Given this list of marker genes Bmp6, Mepe, Nfe2, Bglap2, Actn3, Txlng, Calcr, Intu, Enpp1, Trpm4, Ccn1, Fzd9, Rflna, Gata1, Prl, Gpm6b, Lrp6, Fgfr3, Dlk1, Oxt, Ptger4, Zmpste24 (zinc metallopeptidase, STE24), Smad3, Csf1, Calca, Tgfb1, Bcor, Bmpr2, Fbn2, Smad6, Fgf23, Mkx, Ltf, Smurf1, Gdf10, Atraid, Ccdc134, Ccr1 (C-C motif chemokine receptor 1), Tob2, Smad2, Kremen1, Suv39h1, Rxrb, Nell1, Bglap3, Ahsg, Sfrp1, Sgms2, Rsad2, Creb3l1 (cAMP responsive element binding protein 3-like 1), Mapk1, Gja1, P2ry2, Srgn, Tent5a, Matn1, Cnmd, Bmp2 (NCBI Gene Id 98992), Asxl2, Adrb2, Osr1, Chsy1, Osr2, Grem1, Acvr2a, Fam20c, Sox9, Setd2, Runx2, Egr2, Ccr1l1, Slc8a1, Atp2b1, Comp, Ptk2b, Tacr1, Thrb, Wnt5a, Phospho1, Nipbl, Wnt4, Pth, Ano6, Mdk, Pkdcc (protein kinase domain containing, cytoplasmic), Nbr1, Bmpr1a, Dhrs3, Bglap, Isg15, Ostn, Mia3, Mapk3, Tmem53, Pbx1, Vdr, Ptpn11, Tac1, Notch1, Tmem119, Adgrv1, Bcl2, Ccn3, Ddr2, Adcy10, Dkk1 (NCBI Gene Id 13380), Alox5, Lrp4, Bmp7, Twist1, Mgp, Acvr1 (NCBI Gene Id 11478), Tfap2a, Ptn, Mapk14, Ltbp3, Notum, Sox11, Zbtb16, Hif1a, Six2, Rflnb, Tph1, P2rx7, Ecm1, Acvr2b, Kremen2, Slc20a2, Cd276, Smad7, Bmp4, Kl, Ank (NCBI Gene Id 52488), Rbpj, Mef2c, Sost, Csf1r, Wnt10b, Acvr1b, Bmpr1b, Cyp27b1, Esrra (estrogen related receptor, alpha), S1pr1, Ifitm5, Gfra4, P3h1, Scube2, Rxra, Bmp2k, here is a description of the gene set: species: Mus musculus Any process that modulates the frequency, rate or extent of ossification, the formation of bone or of a bony substance or the conversion of fibrous tissue or of cartilage into bone or a bony substance. Mouse Gene Set: GOBP_REGULATION_OF_OSSIFICATION